Given this list of marker genes LINC01387, ARHGAP28-AS1, RNU6-1210P, DLGAP1-AS2, MPPE1, KIAA0895LP1, LINC01882, ARHGAP28, TUBB8B, BNIP3P3, LINC01444, ENSG00000265069 (novel transcript, antisense to LAMA1), TYMS (thymidylate synthetase), LPIN2, SCML2P1, FEM1AP2, RNU6-1021P, MYL12-AS1, CHMP1B, LINC01892, RPL31P59, RNMT, DLGAP1-AS5 (NCBI Gene Id 284215), SPIRE1, THEMIS3P, RNU1-109P, PMM2P1, CEP192, DLGAP1, SLC25A51P2, RPL21P127, LINC01928, ENSG00000267079, RNU7-25P, COLEC12, CLUL1, EMILIN2, METTL4, RNU6-721P, SLC35G4, RNU6-916P, PRELID3A, CIDEA, TOMM20P3, LINC01254, MC5R, MIX23P1, RNU2-27P, LINC00668, NPIPB1P, LONRF2P1, OR4K7P, LINC02974, RPL6P27, TWSG1-DT, MYL12B, RPL36AP49, GNAL, THOC1, TGIF1, RN7SL362P, RN7SL282P, ENSG00000266397, ENSG00000266767, CXADRP3, RNU6-316P (RNA, U6 small nuclear 316, pseudogene), RN7SL39P, VAPA, LINC02564, RNU7-129P, ENSG00000303474, NDUFV2-AS1, CBX3P2, LINC01887, STK25P1, MTCL1, GAPDHP66, ENSG00000212626, ENSG00000199856, RALBP1, PPP4R1-AS1, LAMA1, ANKRD20A5P, ANKRD12, ZNF519, ROCK1P1, BOLA2P1, RNA5SP450, CETN1, LDLRAD4-AS1, ANKRD62, ZNF415P1, PPIAP14, ENSG00000264449, RPS4XP19, RNU6-831P (NCBI Gene Id 106481443), ASNSP6, LINC02979, AFG3L2, MIR4526, FGF7P1, TWSG1, OR4K8P, SMCHD1, IGLJCOR18, PTPN2, PMM2P2, RNA5SP449, PSMG2, TXNDC2, KATNBL1P3, LRRC30, TERF1P2, SEH1L, TUBB6, RNU6-324P, MYL12A, THOC1-DT, AKAIN1, AIDAP3, LINC00526, GTF2IP8, GAPLINC, MIR7153, LINC01904, LDLRAD4, LINC01255, MIR4317, IL9RP4, CYP4F35P, L3MBTL4-AS1, ENSG00000266401, PPP4R1, CHORDC1P4, COX6CP3, RHOT1P1, LDLRAD4-AS2, AKR1B1P6, ENSG00000263745, GRAMD4P7, ENSG00000297276, MIX23P3, RN7SKP72, MIR3976, ENSG00000267694, ANKRD30B, CEP76, IMPA2, EIF4A2P1, ENSG00000309896, RN7SL862P, FAM210A, PPIAP56, LINC01895, MIR3976HG, LINC01906, ENSG00000238575, MIR3156-2 (NCBI Gene Id 100422907), LINC01925, VN1R74P, ADGRA3P1, PIGPP4, SNORA70, TMEM200C, SNRPCP4, MIR6788, ADCYAP1, RN7SL50P, PIEZO2, COP1P1, LINC00667, YES1, LINC00470, CHMP1B-AS1, RNU6-170P, ENSG00000260779, USP14, DLGAP1-AS3 (NCBI Gene Id 201477), SNX19P3, BOD1P2, RNU6-349P, LINC02856, NDC80, MIR5190, NF1P5, ZBTB14, MYOM1, RNU6-340P (NCBI Gene Id 106479717), RAB12, CEP192-DT, DLGAP1-AS1, APCDD1 (APC down-regulated 1), MC2R, TYMSOS, POTEC, ENOSF1, LINC01443, RNU5F-3P, DLGAP1-AS4, ENSG00000294986, L3MBTL4, RN7SKP146, KRT18P8, GACAT2, PTPRM, RAB31, MIR6718, BOD1P1, SLC25A3P3, MIR8078, EPB41L3, ELOCP27, NDUFV2, SDHDP1, RNU6-903P, NAPG, FRG2LP, C18orf15, ENSG00000297316, here is a description of the gene set: studied in species Homo sapiens Human Gene Set: chr18p11